Given this list of marker genes SRSF6, PHF5A, SF3A1, SRPK1, PRPF6, TXNL4A, RNU1-4, ISY1, LUC7L3, RBM5, RNU11, SNRPD1, SRSF12, RNVU1-2A, SRPK2, WEE2-AS1, DDX23, DDX42, SNRPE, BUD13, RNU6ATAC, SF3B5, SFSWAP, SRPK3, SNRPD3, SF3B4, SMN1, SF3A2, PRPF39, KHDC4, GEMIN6, LUC7L, SNRPD2, SF3B1, SF3B2, RNVU1-7, PRPF19, U2AF2 (U2 small nuclear RNA auxiliary factor 2), SLU7, SNRPA1, PUF60, RNVU1-1, NOL3, DDX39B, ZRSR2, YTHDC1, RNVU1-19, PTBP2, RNVU1-6, SCAF11, NCBP1, RNU4ATAC, CRNKL1, SRSF9, CELF3, CELF6, SF3A3, CELF1, RNVU1-3, RNU2-1, SF3B3, HTATSF1, SNIP1, DDX46, RNVU1-15, SMN2, GCFC2, SNRNP200, SNRPF, SNRPG, SNRPB, LUC7L2 (LUC7 like 2, pre-mRNA splicing factor), RNVU1-4, SNRPC, DDX1, SRSF10, CELF5, RSRP1, TAF12-DT, CELF2, SETX, RNVU1-8, SNRPB2, SF3B6, SRSF5 (serine and arginine rich splicing factor 5), USP39 (NCBI Gene Id 10713), RNVU1-14, GEMIN2, RBMX2, CELF4, SRSF1, SF1, PSIP1, RNVU1-17, here is a description of the gene set: species: Homo sapiens The aggregation, arrangement and bonding together of a spliceosomal complex, a ribonucleoprotein apparatus that catalyzes nuclear mRNA splicing via transesterification reactions. Human Gene Set: GOBP_SPLICEOSOMAL_COMPLEX_ASSEMBLY